Given this list of marker genes GPM6B, PRELP, NAMPT, MPG, MLANA, FBXO7, RPLP2, TMEM59, TUBB4B, NECTIN1, DHRS7, ANKS1A, MAD2L1BP (MAD2L1 binding protein), NCSTN, CAPN3, METTL9, TYRO3, BCL2L12, IRS2 (NCBI Gene Id 90066), ATP1A1, PLSCR1, CIAO2A, CHMP2A, HNMT, B3GALT6, BTG1, IGKC, MXI1, RXRG, SLC23A2, PORCN, TM2D1, STXBP1, UBE2V1, TRIB2, ADAM10, FABP4, GAB2, SUOX (sulfite oxidase), LYSET, STX7, MUTYH, FANCG, ST8SIA1, ABI1, CHSY1, HLA-DRA, CASP1, ASAH1, CD163, RPGR, HEXA, HPS4, ATP6V1B2, SYPL1, ZBTB40, IRF2, VEGFA, DENND2D (NCBI Gene Id 79961), PARP4, LAMP2, RNF14, SLC25A13 (NCBI Gene Id 10165), ACSL3, RYBP, RHOQ, LPIN1, FRMD4B, MTMR6, VPS36, TMX4, SAA4, CRYL1, GYG1, PIKFYVE, KCNN4, ST3GAL4, ENTREP1, PYGB, here is a description of the gene set: studied in species Homo sapiens Human Gene Set: MODULE_491 Genes in the cancer module 491.